Given this list of marker genes Kcnc1, Kcnc4 (potassium voltage gated channel, Shaw-related subfamily, member 4), Scn10a (NCBI Gene Id 208230), Kcna1, Kcna2, Kcnq5, Kcnj8, Kcnh1, Kcnj11, Kcnc2, Kcnj3, Rimbp2, Scn1a, Kcnmb4, Kcna4, Kcnj6, Scn2a, here is a description of the gene set: species: Mus musculus Mouse Gene Set: GOMF_VOLTAGE_GATED_MONOATOMIC_ION_CHANNEL_ACTIVITY_INVOLVED_IN_REGULATION_OF_PRESYNAPTIC_MEMBRANE_POTENTIAL Voltage-gated ion channel activity, occurring in the presynaptic membrane, involved in regulation of presynaptic membrane potential. This is a key step in synaptic transmission, following the arrival of an action potential at the synapse.